The following is a description of a gene set: studied in species Mus musculus Mouse Gene Set: MP_INCREASED_TUMOR_GROWTH_SIZE from publication Motenko H, Neuhauser SB, O'Keefe M, Richardson JE (PMID 26092688) Mouse genes annotated to increased tumor growth/size (MP:0003721) retrieved from the Mouse Genome Informatics database via MouseMine, and this is the list of marker genes: Plcl1, Lyg1 (lysozyme G-like 1), Itgb3, H19, Trim16, Plk3, Mki67, Ticam1, Tnfsf10, Cebpa (CCAAT/enhancer binding protein alpha), S1pr2, Lrg1, Rras, Tgm2, Cd160, Apc, Icam1, Paqr3, Sell, Prf1, Cdkn2a, Pdcd1lg2, B3gnt6, Ifnar1, Mir122, Nr4a1, Fkbpl, A4gnt, Layn (layilin), Pard3, Ppargc1a, Rnf19b, Postn, Cd226, Gpr68, Mbd3, Cygb, Gzma, Kit, Klhl22, Stard13, Il22ra2, Cxcl16, Fos, Ifnb1, Itga6, Map3k8 (NCBI Gene Id 26410), Adamts12, Hdac11, Elavl1, Klf10, Sparc, Bub1b